The following is a description of a gene set: studied in species Mus musculus The aggregation, arrangement and bonding together of a set of components to form the endoplasmic reticulum (ER) tubular network. The ER tubular network is the ER part that comprises the membranes with high curvature in cross-section. Mouse Gene Set: GOBP_ENDOPLASMIC_RETICULUM_TUBULAR_NETWORK_FORMATION, and this is the list of marker genes: Rtn4, Zfyve27, Rtn2 (reticulon 2 (Z-band associated protein)), Arl6ip1, Rtn1, Rtn3